The following is a description of a gene set: Any structural abnormality of the coronary arteries. Human Gene Set: HP_ABNORMAL_CORONARY_ARTERY_MORPHOLOGY species: Homo sapiens Abnormal coronary artery morphology, and this is the list of marker genes: APOA2, PRKG1, PPARG, PNPLA2, CYP7A1, ACTA2, TKT, MYH11, TGFBR1, TGFB3, LMX1B, FBN1, MYLK, XYLT2, SMPD1, MEF2A, LRP6, BRCC3, LDLRAP1, LDLR, GHR, TBX5, YY1AP1, APOA1, CEP19, HGD, ANAPC7, ELN, LZTR1, ABCG8, NT5E, NADSYN1, SMAD4, MFAP5, EPHX2, FOXE3, MAT2A, APOB, ERCC8, SERPIND1, LOX, MLXIPL, GPIHBP1, POLR1A, APOE, ZNF687 (NCBI Gene Id 57592), THSD4, ABCG5, ABCC6, XYLT1, ENPP1, PLXND1 (NCBI Gene Id 23652), PPP1R17, TGFB2, ABCA1, ERCC6, PPFIBP1, NKX2-6, CELA2A, ESR1 (NCBI Gene Id 2099), DYRK1B, SMAD3, EHMT1, LMNA, CIROP, CYP27A1, GLB1, SMAD2, PCSK9, TGFBR2, LIPC, TBX1, HEY2